Given this list of marker genes TMEM255A, DZANK1, MSX1, LYG1, SMAD9, CARF (calcium responsive transcription factor), RECQL5, TRPV6, SLA2, NGF, YPEL1, ASIC4, EGFLAM, FAT2, INPP5A, PGK2, COL11A2, OLIG1, ABLIM2, FNDC9, ST6GALNAC2, STAC3, ARC, NEFH, ATP7B, SIX3, PCDHB7, EDNRA, FLVCR2, CCDC172, ADAMTS2, KCNK5, NT5E, NEFM, USP50, KIF6 (kinesin family member 6), ADAM32, MIA, ARHGAP33, GGT7, PNPLA5, RIMBP2, ANK2, CLSTN1, NOG, DCAF12L1, GNAO1, C4orf36, HTR5A, ADAM18, TMEM200A, FAM43B, TRPM3, CYP24A1 (cytochrome P450 family 24 subfamily A member 1), CNR1, FGFRL1, ARHGAP42, CBFA2T3, CYP4A22, GRIK3, VDR, TIMD4, WSB1, CEND1, PLPP4, FANCC, GCHFR, ANKRD55, CRISPLD1, PDX1, MARVELD3, UQCRC1, TLCD4, CD226 (CD226 molecule), DSCAML1, STK33, TAFA1, DKK3, TOM1L1, TMOD2, MYL6B, KRT24, TESMIN (testis expressed metallothionein like protein), PAPLN, SEPTIN2, MIR124-1HG, INSM1, HHIPL1, TTPA, FGFBP1, EXOSC6, ADGRA1, CLEC2L, ATP13A4 (NCBI Gene Id 84239), CES3, HIP1R, SYT17, INSYN2A, SCN4B, KCNH8, FAM149A, GEMIN7, PSD2, LDHAL6B (lactate dehydrogenase A like 6B, NCBI Gene Id 92483), MYMK, KRTAP2-4, CAPN9, CYP17A1, ITIH1, TNXB, PKHD1L1, CXCR2, REG1A, SELP, SPATA6L, C2CD4C, BAIAP2L1, RAB39A, BIRC7, ZNF334, BMX, ARHGEF28, MYO18B, SPAG8, HPDL (4-hydroxyphenylpyruvate dioxygenase like), SLC22A13, FZD2, USP49, GRIK2, SEPTIN12, GABRB3, NKD2, TMEM238L, KCNJ16, SPINK4, OLFM3, CADM3, BARX1, AQP5, ANGPTL7 (angiopoietin like 7), ACSL6, ERP27, CUZD1, EPX, NRTN, KRT23, KIF21A, CCDC87, CFD, MIPEP, MAP6D1, DNAAF8, SYT8, CD53, HPD, TUB, SLC38A5, TDRD9, TMTC1, RSPH1, DRC3, TBC1D4, SDK1, FOXA3, HIRA, ADAMTS4, INHBC, ADAMTSL2, CACNA1D, BAG6, SCGB1A1, GPR35, SCUBE1, GPAT4, ACTL9, RANBP17, DHTKD1, OAZ3, CFAP184, PNOC, ACHE, C22orf23, PCNX2, CCR7, ZNF239, TRPM5, GRPR, SRPX, UBL4B, ABRAXAS1, C4orf19, CD8B, SLC35F1, DNAH6, ZNF473, DBX2, SPMIP5, SHC2 (SHC adaptor protein 2), HSPB3, ALLC, here is a description of the gene set: The activation signaling of transcription factor nuclear factor-kB (NF-kB) plays central role for immune system. One of key kinase mediating this pathway is TAK1 in adaptive and innate immunity. However, role of TAK1 in B cell receptor signaling is still unclear. To know effects of TAK1-deletion on the gene expression induced by anti-IgM, we performed the time course analysis in comparison of wild type with TAK1-deleted splenic B cells. studied in species Homo sapiens Human Gene Set: GSE41176_UNSTIM_VS_ANTI_IGM_STIM_TAK1_KO_BCELL_6H_DN Genes down-regulated in B lymphocytes with MAP3K7 knockout: untreated versus anti IgM for 6h. from publication Shinohara H, Behar M, Inoue K, Hiroshima M, Yasuda T, Nagashima T, Kimura S, Sanjo H, Maeda S, Yumoto N, Ki S, Akira S, Sako Y, Hoffmann A, Kurosaki T, Okada-Hatakeyama M (PMID 24833394)